Given this list of marker genes Tyrp1, Bcl2, Mef2c, Hps1, Cited1, Or51e2, Kitl, Gna11, Ednrb, Mlph, Sox10, Kit, Gnaq, Adamts9, Hps4, Adamts20, Bloc1s6, Edn3, Gli3, Oca2, Rab27a, Zeb2, Mitf, Mreg, Myo5a, Enpp1, Lrmda, here is a description of the gene set: species: Mus musculus The process in which a relatively unspecialized cell acquires specialized features of a melanocyte. Mouse Gene Set: GOBP_MELANOCYTE_DIFFERENTIATION